The following is a description of a gene set: species: Homo sapiens Human Gene Set: GOBP_PEPTIDYL_GLUTAMIC_ACID_MODIFICATION The modification of peptidyl-glutamic acid., and this is the list of marker genes: AGBL2, TTLL1, AGBL4, NAA20, VKORC1L1, TTLL4, CFAP20, TTLL8, FOLH1B, TTLL6, AGBL3, AGBL5, VKORC1 (vitamin K epoxide reductase complex subunit 1), TTLL7, CEP41, TTLL3, FOLH1, AGTPBP1, AGBL1, NAA80 (N-alpha-acetyltransferase 80, NatH catalytic subunit), TTLL10